The following is a description of a gene set: Human Gene Set: GSE37301_CD4_TCELL_VS_GRANULOCYTE_MONOCYTE_PROGENITOR_UP species: Homo sapiens Expression profiling of Rag2-deficient Ets1++ and Rag2-deficient Ets1-- mature NK cells and WT bone marrow progenitors, WT T cells, and WT Pro B cells Genes up-regulated in CD4 versus granulocyte-monocyte progenitors. from publication Ramirez K, Chandler KJ, Spaulding C, Zandi S, Sigvardsson M, Graves BJ, Kee BL (PMID 22608498), and this is the list of marker genes: NCKAP5L, GFOD2, CHD7, ATP8B4, ZBTB7B, IKZF1 (NCBI Gene Id 55429), CD40LG, EME2, UNC5A, XYLT2, SLC26A11, KRT16, ELOVL7, DSE, ARHGAP4, ZFHX4, TMIE, PROP1, RGS11, ABTB3, PLEKHF2, RFLNB (refilin B), PEG10, PAG1, HS3ST5, IL23A, MCTP2, APPL2, KLRD1 (killer cell lectin like receptor D1), GPR18, CYB5RL (cytochrome b5 reductase like), CIMIP7, PCYOX1, LEF1, SNN, PREX1, SGK1, ANKRD13D, GRK6, APP, GGT5, ADH1A, P2RX5, DENND3, ADCY6, AP1M2, COMMD8, BBS9, GABRA5, SLC16A10, TSPAN14, RNF144A, RINL, CTNNA2, FAM78A, UBD (NCBI Gene Id 95374), LRRC23, ABHD15, PDE3B, CORO1C, TACC2, TARBP2, RIPOR2, SELENOP, RABGGTA (NCBI Gene Id 5875), CMBL, HS3ST3B1, SLC16A7 (NCBI Gene Id 9194), ARPC1B, PADI2, NR2E1, TNFRSF1A, UBE2E2, TECPR1, SLC16A5, HDAC5 (NCBI Gene Id 23342), TSPYL4, OAS2 (2'-5'-oligoadenylate synthetase 2), DAPL1, THEMIS, IGFBP4, TGFBR3, ALS2CL, NLK, SCP2, ST3GAL1, ELF1, CLIP1, FCRLB, GGT1 (NCBI Gene Id 91347), PFKFB4, SEMA4F, ATP1B1, LAIR1, LYNX1 (Ly6/neurotoxin 1), ZBTB9, SLC12A7, JUP, GK2, PPIC, GPR183, DNAJC6 (DnaJ heat shock protein family (Hsp40) member C6), DOLPP1, FAAH, SPOP, SLC20A1, QPCT, MAN2A2, MAML3, BHMT (betaine--homocysteine S-methyltransferase), PAFAH2, GTF2I, MSRA, VIPR1, SLCO3A1, MYO10, ST8SIA1, FBXO27, PDK1, DOK6, RANBP10, METTL9, RAVER2, SEMA4A, BEND4, RCC1L, GPR149, LYPD6B, CLCF1, MIR99A (NCBI Gene Id 407055), EYA2, DDR1, ATP4A, PIK3R5, ACVRL1, MAML2, CMAHP, RNF32, SCML4 (NCBI Gene Id 256380), RTN4RL1, N6AMT1, ATP2A3, XKRX, CRTAM, AMPD1, WDR13, MYLIP, EHD3, ARHGAP29, MBOAT1, OSBPL5, DPH5 (diphthamide biosynthesis 5), ITGB3, GRK2, NANOS1, IHO1, ARHGEF18, RASGRP2, SLC37A2, RAPGEF4, TCF7, GALNT10